The following is a description of a gene set: Human Gene Set: HP_HYPOPLASTIC_SPLEEN Hypoplastic spleen Underdevelopment of the spleen. studied in species Homo sapiens, and this is the list of marker genes: CLXN, RELN, SAMD9, STRA6, MCM10, KATNB1, AIRE, FAM111A, STIM1, NDE1